Given this list of marker genes NR3C1, DCDC2, CYP27A1, TMEM67, ATRX, SPTBN1, CDH23, CHRNB2, KCNT1, BRAF, USP8, CABP4, DEPDC5, CHRNA4, CHRNA2, CRH, CEP85L, TP53, HTT, DCTN1, SLC2A3, FIG4, USP48, here is a description of the gene set: Frequent thoughts about or preoccupation with killing oneself. studied in species Homo sapiens Suicidal ideation Human Gene Set: HP_SUICIDAL_IDEATION